The following is a description of a gene set: Human Gene Set: GOBP_DIACYLGLYCEROL_CATABOLIC_PROCESS studied in species Homo sapiens The chemical reactions and pathways resulting in the breakdown of diacylglycerol, a glyceride in which any two of the R groups (positions not specified) are acyl groups while the remaining R group can be either H or an alkyl group., and this is the list of marker genes: DAGLA, DGKD, LIPE, PLB1, DAGLB, APOA2